Given this list of marker genes IL17RD (interleukin 17 receptor D), FLRT1, TMEM168, PSMC2, MKRN1, NLGN4Y, PTGES3, IL24, LZTS3, TUBA8, PLEKHO2, TCF7L2, HNRNPC, CSNK1D, PTGFR, MDFI, ARL17A, CTSS, CFAP298, QNG1 (NCBI Gene Id 84267), EDARADD, HDGF, ST7L, PGM2L1, CNTD1, DOCK2, CCDC86, ITM2B, DDX3Y, SERPINB13, HS3ST5, SGCB, TMEM214, RAB41, APOBEC3C (apolipoprotein B mRNA editing enzyme catalytic subunit 3C), TMEM243, PIAS3, here is a description of the gene set: Genes predicted to be targets of miRBase v22 microRNA hsa-miR-3135a in miRDB v6.0 with MirTarget v4 prediction scores > 80 (high confidence targets). from publication Chen Y, Wang X (PMID 31504780) studied in species Homo sapiens Human Gene Set: MIR3135A